Given this list of marker genes PYM1, PPP1R14D, C1orf21, ELAVL1, CHD6, PLSCR3, GNAO1, RELCH, ZNF646, SCD, LURAP1L, HOXC6, TLE1, MLLT6, DCX, ZNF664, SASH1, ZFYVE1, NFIB, HSPG2, BBS12, PLPPR1, HYAL2, SSBP3 (NCBI Gene Id 55126), RELT, UBE3A, CASK, NGFR, PAK1, SLIT2, DDX6, DPYSL2, ARHGEF19, KRT14, STK38L, TEK, FN1, CTNNB1, LHX6, RHOBTB1, RBBP4, EHBP1, TSC22D3, ZIC2, SOX4, PER1, LRRN1, PDS5B, NEUROD2, EPHB6, RREB1, LINC01597, EFNA1, PNRC1, HDAC9, KLHL13, NOL4L, CCDC92, NEUROD6, HHEX, SYT4, MYO18A, MARCKSL1, KCNB2, TNPO1, KAT6A, DLX1, USP25, GJC2, ELAVL4, CYRIA, RAB5A, SORBS2 (NCBI Gene Id 8470), DMD, FBLN5, CELF3, ZNF711, SOX5, SLC39A9, RGS3, ELAVL2, FLRT3, RTN4, HOXA2, SEC24C, ZSCAN2, CBFA2T2, ZIC1, TSPAN2, TIA1, N4BP1, PABIR1, DLC1, RERE, OLFM1, NR4A1, ZDHHC9, MAST1, CDON, PARP8, CDKN1B, NFIX, TNNI2 (troponin I2, fast skeletal type), KLF3-AS1, ZNF277, TAL1, ERH, DNAJA2, TCL1A, PICALM, PPP2R2B, NAA38, KLK3, ILF2 (NCBI Gene Id 3608), TLX3, ETV1, DUSP6, MAOB, CASC2, PTPN12, RBFOX2, FBXL19-AS1, SYTL2, PDE9A, CCM2L, DAAM1, KCNN2, DTX1, CER1, NAV1, APBA1, VLDLR, MFAP5, MLLT11, SPATS2, FEN1, AMER1, LARP4 (La ribonucleoprotein 4), G2E3, DOCK4, PRKCH, SEMA6C, TRIM8 (NCBI Gene Id 81603), ZIC4, HMGB1, TOP2A, MEIS1, SKAP1, CCDC85B, HOXA10, ABCF2, PCDH12, FANK1, ZBTB8OS, SLC13A5, MYCT1 (NCBI Gene Id 80177), CDK8, WEE1, PELI2, HOXB7, MAML1, CCNJ, DPYSL5, G3BP2, PTMA, CDC42SE1, FGFR2, MYT1, GRK5, PBX1, TMEM88, ERG, TOP1, FGFR1, MEX3D, NDP, E2F1, FAM53C, MAP4K4, ZNF668, PPP1R16B, TMEM258, BCL11B, TFAP2B, DGKA, EGFLAM, POLB, MBP (myelin basic protein), FSIP2, RLIM, FST, SLC39A14, CHL1, INHBA, CADM1, BSN, TBX6, ADRB2, SIX1, HOXC10, CPNE1, KIF20B, TRIB2, TMEFF1, CYB5D1, PFN2, ACVR2A, EDA, PCBP2, SEPHS1, MARCKS, DENND2C (DENN domain containing 2C), PHC1, SH3BP1 (SH3 domain binding protein 1), NASP, KLF3, RCN1, STC1, BCL2L11, EBF1, NECAP1, MAP3K3, SPTBN1, SOX2, ZNF502, CD36, BASP1, CADPS, NEO1, ARF4, TEAD1, BPTF, DHX40, PUM1, RBM39, OTUD7B, FBN2, MTF2, NCAM1 (neural cell adhesion molecule 1), here is a description of the gene set: Human Gene Set: SOX9_B1 Genes having at least one occurrence of the motif NNNNAACAATRGNN in the regions spanning 4 kb centered on their transcription starting sites. This matches the SOX9 transcription factor binding site V$SOX9_B1 (v7.4 TRANSFAC). studied in species Homo sapiens